The following is a description of a gene set: Human Gene Set: chr2q32 species: Homo sapiens, and this is the list of marker genes: STK17B (NCBI Gene Id 9262), LINC01090, PCGEM1, NEMP2-DT, RPL21P32, RN7SL267P, HECW2-AS1, PDE1A, INPP1, DPRXP1, RN7SL820P (NCBI Gene Id 106480535), NABP1, E2F3P2, ENSG00000283839, ORMDL1, OSGEPL1, NEMP2, ELF2P4, SEC61GP1, CALCRL-AS1, ENSG00000221498, FSIP2-AS1, CALCRL, C2orf88, KRT18P19, CAVIN2, CACYBPP2, LINC01827, FAM171B, NAB1, RNF11P1, HIBCH (3-hydroxyisobutyryl-CoA hydrolase), RNU6-959P, STAT1, ZSWIM2, ENSG00000212581 (U8 small nucleolar RNA), HNRNPA1P47, KRT8P10, COL5A2, RPL23AP35, DUSP19, DNAJC10, LINC01821, RAB1AP1, LINC01790, SLC44A3P1, RNU6-1122P, GLULP6, COL3A1, ENSG00000305283, MED28P3, DNAJC17P1, NUP35, HMGB1P27, MSTN, MYO1B, LINC01473, GULP1, MIR548AE1, ZNF804A, AHCYP5, RNU6-989P, MIR1245B, DNAJB1P1, DNAH7, RN7SKP179, GAPDHP59, GLS, MIR3606 (microRNA 3606), RPS17P8, NCKAP1, SLC39A10, ENSG00000310088, LINC01825, HNRNPCP2, IMPDH1P7, MYO1B-AS1, HECW2, RNA5SP114, ENSG00000252517, ENSG00000225884, RNU6-169P, KDM3AP1, RNU6-1045P, CAVIN2-AS1 (NCBI Gene Id 105373813), MFSD6, ITGAV, SLC40A1 (NCBI Gene Id 56414), LIN28AP1, RPL31P15, MIR561, ST13P2, TMEFF2, ASNSD1, STAT4-AS1, MIR3129, OSGEPL1-AS1, WDR75, TERF1P6, FRZB, MIR1245A, PMS1, ASDURF, ZC3H15 (NCBI Gene Id 55854), RNU6-915P, DIRC1, RN7SKP42, FSIP2, TFPI, ANKAR, STAT4, RPL23AP33